Given this list of marker genes NOS1, PCARE, TULP1, RDH12, DRAM2 (DNA damage regulated autophagy modulator 2), INHA, GUK1, SAG, KIFAP3, MAGI2, GNGT1, ASRGL1, CEP250, PHLPP2, ARR3, MYO3B, GUCA1A, ZBED4, GNAT2, USH2A, CFAP418, ARMS2, USP45, IMPG1, PRPH2, OPN1SW, RHO, ATP1A1, SNAP25, PPEF2, RCVRN, MAK, GUCA1B, ADGRV1, USH1G (NCBI Gene Id 140471), SHANK2, GUCA1ANB-GUCA1A, BSG, KIF17, REEP6 (NCBI Gene Id 92840), CIB2, MYO3A, CCDC66, EPB41L5, SLC2A1, RP1, STX3, USH1C, FAM161A, CROCC, BBS4, RD3, RDH11, ATP1A3, RS1, ENO2, PIP4K2A, PDC, CDH23, AIPL1, HKDC1, ATP1B2, WHRN, KIAA0586, SLC24A2, CRB1, MYO7A, CERKL, GNAT1, here is a description of the gene set: studied in species Homo sapiens Human Gene Set: GOCC_PHOTORECEPTOR_INNER_SEGMENT The inner segment of a vertebrate photoreceptor containing mitochondria, ribosomes and membranes where opsin molecules are assembled and passed to be part of the outer segment discs.